Given this list of marker genes PSEN2, AURKA, AGO3, AIMP2, ESPL1, NCAPH, DTL, TYMS, MCUR1, BMAL2, MIS18A (MIS18 kinetochore protein A), MCM5, MED14, GPR19, ZNF248, IL2RA (NCBI Gene Id 3559), METTL13, ERCC6L, BIRC5, GK, DSN1, PPCDC, AFG2B, CPPED1, CDC45 (cell division cycle 45), PAICS, TXN, CDCA8, MAP7D3, CDCA3, CDKN3, CENPA, PFAS, DHFR, SMC1A, GBA1LP, GINS2, LAMP3, ACOT7, TRAIP, ACAA2, STMN1, RFC4, DUT, TNFAIP1, KIF20A, CENPE, BDH1, SLC25A5, PGAM1, POLQ, CTPS1, TTI2, FH, PSMB2, STT3A, PCLAF, KIF2C, TALDO1, OIP5, TMEM106C, IMMT, POLE2, MCM7, PXMP2, MEAK7, POLA2, CISD1, TUBA1C, FIBP, KIF11, CEP55, DNAJB6, SLC43A3, UMPS, JPT2, BUB1, MYB, CENPM, IFI30, ZNF706, MLEC, EGR3, MCM2, CTNNA1, SAP30 (Sin3A associated protein 30), ACO1, ACTG1, FOXM1, RAD51, RAD51AP1, VDR, CKAP5, PAFAH1B2, GCNT1, TJP2, ZBED2, EXOSC4, SRSF1, GRK3, PTTG1, TPGS2, GLA, RB1, UBE2C, RPA3, SFT2D2, GLRX2, APOLD1, BATF3, POLA1, SMCO4, TTF2, ZWINT, NME1, CEP15 (centrosomal protein 15), STIL, PCK2, TPM4, RAD51D, IL1R1, MRPL35, TUBB6, NUSAP1, EXTL2, RAD54L, FANCI, MCM10, DTYMK, CENPS, TPI1, DCTPP1, DLGAP5, PBK, CCDC51, NCAPG, CORO1C, FABP5, FAH, UBFD1, TIMM10, POLR2H, SAC3D1, ELOVL6, LMNB2, TST, GMNN, DPP3, KIF15, CDC6, TTK, BATF, HSPA1A, CKS1B, MYL6, RBM4B, CCNB1, TARS1, CKS2, KIF3B, CDC25A, BUB1B, RPP40, SHCBP1, SPAG5, LBHD1, WARS1, FBXO5, SRM, MYCBP, GPN3, PCNA, FEN1 (flap structure-specific endonuclease 1), MKI67, TOP2A, MYL6B, CDC20, IL1R2, RBBP8, GSTO1, LGMN, FANCL, NEIL3, KIFC1, GGH, HMMR, TUBA1B, CCNB2, RRM2, TBL2, HMGB3, NQO1, ASPM, MYOF, TUBG1, CHEK1, MRPL19, TK1, DHX32, HILPDA, here is a description of the gene set: from publication Yu M, Li G, Lee WW, Yuan M, Cui D, Weyand CM, Goronzy JJ (PMID 22434910) Genes down-regulated in comparison of untreated CD4 memory T cells from young donors versus those treated with TSST at 72 h. With increasing age, the ability of the immune system to protect against recurring infections or to control chronic infections erodes. The objective of the current study was to identify gene expression signatures in elderly CD4 T cell responses Human Gene Set: GSE36476_CTRL_VS_TSST_ACT_72H_MEMORY_CD4_TCELL_YOUNG_DN studied in species Homo sapiens